The following is a description of a gene set: Human Gene Set: GOBP_NEUROMUSCULAR_SYNAPTIC_TRANSMISSION The process of synaptic transmission from a neuron to a muscle, across a synapse. studied in species Homo sapiens, and this is the list of marker genes: CHRNA1, P2RX3, P2RX2, FCHSD1, CHRM1 (cholinergic receptor muscarinic 1), ADARB1, RAPSN, KIF1B, RIMBP3, CHRNB2, STXBP1, TSPOAP1, STAC3, CHRNB4, MYLK2, ETV5, CHRNA6 (cholinergic receptor nicotinic alpha 6 subunit), RIMBP3B, RAB3A, CHRNA2, EGR3, CHRNA7, CHRNB3, VPS54, RIMBP2, CHRNA3, FCHSD2, SLC5A7, CHRNA5, CHAT, DTNA, CHRNB1 (cholinergic receptor nicotinic beta 1 subunit), RIMBP3C, NRXN1, LARGE1, CHRNA4, NLGN1